Given this list of marker genes ERCC6, ADAMTS10, LTBP2, ADAMTS17, RDH5, FOXC1, COL4A4, ASPH, RRAGC, LAMB2, PAX6 (NCBI Gene Id 5080), CRYAB, TRIM44, COL4A3, ERCC8, RHO, COL4A5, PRPH2, COL4A6, FBN1, RLBP1, OCRL, here is a description of the gene set: Abnormality of lens shape An abnormal shape of the lens. species: Homo sapiens Human Gene Set: HP_ABNORMALITY_OF_LENS_SHAPE